Given this list of marker genes Abcg2, Slc43a3 (NCBI Gene Id 58207), Slc47a1 (NCBI Gene Id 67473), Abcc6, Abcb5, Slc18a2, Slc47a2, Slc2a1, Abcc5, Slc22a1, Slc17a3, Ralbp1, Abcb1a, Slc22a2, Abcb1b, Abca3, Slc29a4 (NCBI Gene Id 381743), Abcc4, Abcc2, Abca8b (ATP-binding cassette, sub-family A member 8b), Abca8a, Slc22a6, Abcc10, Abcc1, Slc19a1, Slc37a3, Slc18a1, Slc46a1, Slc22a8, Abcb11, Abcc3, Atraid, Slc31a1, here is a description of the gene set: Mouse Gene Set: GOMF_XENOBIOTIC_TRANSMEMBRANE_TRANSPORTER_ACTIVITY studied in species Mus musculus Enables the directed movement of a xenobiotic from one side of a membrane to the other. A xenobiotic is a compound foreign to the organism exposed to it. It may be synthesized by another organism (like ampicilin) or it can be a synthetic chemical.